The following is a description of a gene set: from publication Sasaki Y, Naishiro Y, Oshima Y, Imai K, Nakamura Y, Tokino T (PMID 15856012) p63 and p73 show a high degree of structural homology to p53 and are members of a family of transcriptional factors that can activate transcription of p53-responsive genes. p53 is mutated in more than 50% of human cancers, whereas p63 and p73 are rarely mutated. Studies of knockout mice also revealed an unexpected functional diversity among the p53 family. To determine how p63 and p73 are involved in tumorigenesis and normal development, we used cDNA microarray to examine genes in human colorectal cancer cells. We discovered that the expression of pigment epithelium-derived factor (PEDF) was specifically induced by either p63 or p73, but not by p53. We also report here that the PEDF gene contains a response element specific for p63 and p73 in its promoter region and is a direct target of p63 and p73. Collectively, p63 and p73 may be involved in cell fate by inducing PEDF expression. species: Homo sapiens Human Gene Set: SASAKI_TARGETS_OF_TP73_AND_TP63 Genes up-regulated in DLD1 cells (colon cancer) by p73 beta or by and p63 gamma but not by p53., and this is the list of marker genes: IL4R, ITGB1, MT1X, DUSP7, JAG2, ATM, MT1H (NCBI Gene Id 727730), SERPINF1, CCN1, MEF2B, MT2A, JAG1